The following is a description of a gene set: studied in species Mus musculus from publication Yevshin I, Sharipov R, Kolmykov S, Kondrakhin Y, Kolpakov F (PMID 30445619) Mouse Gene Set: ZFP932_TARGET_GENES, and this is the list of marker genes: Ugt8a, Nxf1, Trav3-4, Gm12647 (predicted gene 12647), Esrrb, Tsc22d1, Cep70, Gm18665, Pla2g6, Stox2, Gm24179, Amd1, Ephb3, Bglap3, Gm17743